The following is a description of a gene set: Human Gene Set: GRANDVAUX_IRF3_TARGETS_UP Genes up-regulated in Jurkat cells (T lymphocyte) by expression of a constitutively active form of IRF3. Ubiquitously expressed interferon regulatory factor 3 (IRF-3) is directly activated after virus infection and functions as a key activator of the immediate-early alpha/beta interferon (IFN) genes, as well as the RANTES chemokine gene. In the present study, a tetracycline-inducible expression system expressing a constitutively active form of IRF-3 (IRF-3 5D) was combined with DNA microarray analysis to identify target genes regulated by IRF-3. Changes in mRNA expression profiles of genes were monitored after Tet-inducible expression of IRF-3 5D. Among the genes upregulated by IRF-3 were transcripts for several known IFN-stimulated genes (ISGs). Subsequent analysis revealed that IRF-3 directly induced the expression of ISG56 in an IFN-independent manner through the IFN-stimulated responsive elements (ISREs) of the ISG56 promoter. These results demonstrate that, in addition to its role in the formation of a functional immediate-early IFN-beta enhanceosome, IRF-3 is able to discriminate among ISRE-containing genes involved in the establishment of the antiviral state as a direct response to virus infection. studied in species Homo sapiens from publication Grandvaux N, Servant MJ, tenOever B, Sen GC, Balachandran S, Barber GN, Lin R, Hiscott J (PMID 11991981), and this is the list of marker genes: NR3C1, IFIT1, PMAIP1, ISG15, AHNAK, GBP1, PLCG2, IFI44, IFIT3, F13B, B4GALT5, OAS2, ARG2